Given this list of marker genes Ppp1r3e, Ppp4c, Ppp2r5c, Ppp2r1b, Ppp2r2b, Ppp1r3b, Ppp3r2, Akap5, Ppp1r10, Ppp1cb, Ppp1r15b, Ppp2r5a, Ppp1r3g, Ppp2r5e, Ppp2r2a, Ptpa, Ier5, Ppp2r2c, Ppp2ca, Ppp2r3d, Wdr82, Mras, Ppp1ccb, Cnep1r1, Nck1, Ppp1cc, Ppp2r3a, Ppp1r12a, Ppp2r2d, Ppp1r15a, Ctdnep1, Ppp3r1, Ppp4r3a, Ppp4r4, Ppp2r1a, Ppp1r3d, Nkd1, Shoc2, Ppp1r3c, Ppp1r3a, Ppp4r3b, Ppp3cb, Ppp1r3f, Ppp2cb, Ppp2r5d, Itpr1, Ppp1ca, Ppp2r5b, Ppp4r3c1, Ppp4r2, Ppp4r3c2, Tox4, Ppp3ca, Ppp3cc, here is a description of the gene set: A protein complex which is capable of phosphatase activity. species: Mus musculus Mouse Gene Set: GOCC_PHOSPHATASE_COMPLEX